Given this list of marker genes CTSL, LGALS3, CD44, STAT6, EGFR, SPARC, HDAC3, MMP1, EZR, ENPP2, CAPG, DNMT1, KLHL41, ARPC1B, here is a description of the gene set: studied in species Homo sapiens Human Gene Set: OZANNE_AP1_TARGETS_UP Cancer motility and invasion genes up-regulated by the AP-1 transcription factor. Metastasis, the aggressive spread of a malignant tumor to distant organs, is a major cause of death in cancer patients. Despite this critical role in cancer outcomes, the molecular mechanisms that control this process are just beginning to be understood. Metastasis is largely dependent upon the ability of tumor cells to invade the barrier formed by the basement membrane and to migrate through neighboring tissues. This review will summarize the evidence that tumor cell invasion is the result of oncogene-mediated signal transduction pathways that control the expression of a specific set of genes that together mediate tumor cell invasion. We focus on the role of the transcription factor AP-1 to both induce the expression of genes that function as invasion effectors and repress other genes that function as invasion suppressors. This identifies AP-1 as a critical regulator of a complex program of gene expression that defines the invasive phenotype. from publication Ozanne BW, Spence HJ, McGarry LC, Hennigan RF (PMID 16799638)